Given this list of marker genes TIPARP, GRK6, HIVEP2, TNFRSF1A, NVL, TIRAP, FLOT1, JUNB, FXYD2, LTC4S, SLC25A36, ARG2, ECE1, HK1, FMNL3, GALE, GART, ADM, TOPBP1 (NCBI Gene Id 11073), PTN, MNS1, AQP7, ABCB1, CSNK1A1, ELOVL6, MKRN1, SEC61A1, HSBP1, P2RY2, RPL36, RNF166, STK16, SLC7A3, RASA1, ZFAND5, MAP3K1, CSTF2, TP53INP2, ORM1, UBE2B, ZNF18, B4GALT3, AHR, WDR74, SARS1, HCK, BNIP3L, RASSF2, RAC2, AZI2, CASP4, TERF2, FDPS, MT2A, RNF138, WDR6, MADCAM1, GJA1, MOB1A, NKAIN1, ETHE1 (NCBI Gene Id 94930), ATP11A, SPSB1 (splA/ryanodine receptor domain and SOCS box containing 1), TLE3, REX1BD, TAX1BP1, ATP1B1, PDZK1IP1, PTTG1IP, CBFB, BCL6, YTHDF2, ZEB1, RPLP0, APAF1, ISG20, SCN3A, TXNIP, FCGR2B, NFIB, ADAM7, ATXN7L3B, PTGER4, H2BC13, GHRL (ghrelin and obestatin prepropeptide), CEBPD, ADAM9, PTBP3, EWSR1, PGM2, GDPD3, TFCP2L1, IL6ST, VAPA, UBE2W, SNX1, MAIP1, AKT2, BCL2L11, ABT1, MAPK6, STAB1, ERO1B, HLA-E, CDKN2B, PISD, RPL23A, SLC11A2, CAP1, ELL, THAP7, GLUD1 (NCBI Gene Id 2746), STAT3, TRAFD1, MAP6, SMARCD2 (SWI/SNF related, matrix associated, actin dependent regulator of chromatin, subfamily d, member 2), TIAM1, XPOT, GLTP, IER2, LDLR, PACRGL, HESX1, PSMC3, KIAA2013, POMP, RERE, LAPTM4A, ARHGEF7, UGCG, PIK3R1, AUP1, FAM13B, TRIM46, CNR2, FECH, BATF, ZNF281, SMIM20, PSME1, F8 (NCBI Gene Id 14069), EVX1, RALGDS, MSRB1, IL1RL1, S100PBP, GPI, PLXNB2 (plexin B2), N4BP1, PFKFB3, GLMP, FLI1, ALDOAP2, SLC46A1, SCAMP1, RPSA, ST3GAL4, CP, TMBIM1, KLHL24, TNFRSF9, GNG2, SSBP4, DUSP2, TIAL1, COQ7, IRF8, ENPP1, AP1AR, TULP4, NAV1, SLC37A4, NAPSA, ZYX, MAP3K3, NSMCE1, CDKN2D, OTULINL, GAB1, CD28, FLVCR2, RPL28, SOWAHC, RSRP1, OSER1, MEF2C, PTGER2, KLHDC2, STBD1, ZFP36, VAV1, SRRT, EBF1, STAT5A, CRISP3, CBX6, MYD88, LGALS2, IST1, LITAF, here is a description of the gene set: Human Gene Set: GSE43955_TH0_VS_TGFB_IL6_IL23_TH17_ACT_CD4_TCELL_60H_DN Despite their enormous importance, the molecular circuits that control the differentiation of Th17 cells remain largely unknown. Recent studies have reconstructed regulatory networks in mammalian cells, but have focused on short-term responses and relied on perturbation approaches that cannot be applied to primary T cells. Here, we develop a systematic strategy – combining transcriptional profiling at high temporal resolution, novel computational algorithms, and innovative nanowire-based tools for performing gene perturbations in primary T cells – to derive and experimentally validate a temporal model of the dynamic regulatory network that controls Th17 differentiation. The network is arranged into two self-reinforcing and mutually antagonistic modules that either suppress or promote Th17 differentiation. The two modules contain 12 novel regulators with no previous implication in Th17 differentiation, which may be essential to maintain the appropriate balance of Th17 and other CD4+ T cell subsets. Overall, our study identifies and validates 39 regulatory factors that are embedded within a comprehensive temporal network and identifies novel drug targets and organizational principles for the differentiation of Th17 cells. species: Homo sapiens Genes down-regulated in CD4 T helper cells (60h): Th0 versus Th17 treated with TGFB1, IL6 and IL-23. from publication Yosef N, Shalek AK, Gaublomme JT, Jin H, Lee Y, Awasthi A, Wu C, Karwacz K, Xiao S, Jorgolli M, Gennert D, Satija R, Shakya A, Lu DY, Trombetta JJ, Pillai MR, Ratcliffe PJ, Coleman ML, Bix M, Tantin D, Park H, Kuchroo VK, Regev A (PMID 23467089)